The following is a description of a gene set: Accumulation of scar tissue within the glomerulus. Human Gene Set: HP_GLOMERULAR_SCLEROSIS Glomerular sclerosis studied in species Homo sapiens, and this is the list of marker genes: WDR19, SDHC, MT-TF, TBC1D8B, RNU7-1, COL4A3, ITGB4, TP53RK, MAX, MT-ND1, ANKFY1, NEK8, RET, MTX2, MT-ND6, SCARB2, SLC37A4 (solute carrier family 37 member 4), NUP160, VHL, ARHGDIA, OSGEP, TMEM127, SDHAF2, NUP133, MAGI2 (NCBI Gene Id 9863), PAX2, NOP10, FH, WDR4, NUP205, DNMT3A (DNA methyltransferase 3 alpha), TREX1 (NCBI Gene Id 82474), PTPRO, MYO1E, TPRKB, ANLN, KIF1B, NUP37, NPHS2, NOS1AP, SDHD, JAG1, NAA10, CD2AP, SGPL1, GON7, COQ6, ACTN4, ELP1, WDR73, MT-TW, PLEC, NUP85, VPS33A, TRIM8, DLST, MT-TS2, SDHB, CRB2, INF2, DAAM2, KIRREL1, NUP107 (nucleoporin 107), COQ8B, CLCN5, NARS2, APOL1, MUC1, SEC61A1, MT-TQ, DKC1 (dyskerin pseudouridine synthase 1), MT-TL1, MDH2, WT1, SMARCAL1, EMP2, LAGE3, EPAS1, LAMB2, NUP93, FAH, BSND, G6PC1, MT-CO1, UMOD, MT-CO2, GAPVD1, CLCNKB, ARHGAP24, MT-ND5, NPHS1, REN, SLC25A11, LAMA5, TRPC6, MT-ND4 (mitochondrially encoded NADH:ubiquinone oxidoreductase core subunit 4), PLCE1, NF1, ITGA3, MT-TH, COQ2, MT-CO3, SLC12A3, LMX1B, SDHA